The following is a description of a gene set: species: Homo sapiens Gait disturbance The term gait disturbance can refer to any disruption of the ability to walk. Human Gene Set: HP_GAIT_DISTURBANCE, and this is the list of marker genes: PLA2G6, SATB2, MFSD2A, CIITA, NGLY1, SMARCA2, PRPS1, MYF6, GDAP1, FKBP14, SGCD, SPATA7, DNM1, DNM1L, DCC, GARS1, CWF19L1, KARS1, KLHL41, GTF2IRD1, UBE4B, LSM11, PIGW (phosphatidylinositol glycan anchor biosynthesis class W), PRUNE1, FZR1, GRM1, PARK7, NEK1, CPLANE1, IL23R, DAO, RIC1, MT-ND2, CBS, STAC3, EMC1, FKRP, DOCK7, MARS2, CDK19, MTM1, SERAC1, NEXMIF, ACOX1, TBL2, SPRY4, SGCG, PROK2 (NCBI Gene Id 60675), USP9X, COPB2, CHMP2B, SAMD9L, FERRY3, FBXO28, ITPR3, BICD2, AIMP2, MT-TQ, CAPRIN1, EEF2, PTCH1, SET, PACS2, SPTAN1, HACD1, SLC1A2, SORD, CHKB, COL10A1, ATP13A2, SLC25A22, RNU12, NDUFAF6, PDK3, OPHN1 (oligophrenin 1), UCHL1, MT-CO1, MT-TV, MT-CO3, NEFL, SLC25A4, DHH, PNPO, CLIP2, KDM5A, TUBB4A, AP2M1, ORAI1, SPEN, SLC35C1, DHX16, OCA2, LAMB2, REEP2, REPS1 (RALBP1 associated Eps domain containing 1), TGFB1, C4A, CASK, PKP1, EIF2AK3, AARS1, TRAF7, NIPA1, SYT2 (synaptotagmin 2, NCBI Gene Id 6858), FUS (NCBI Gene Id 406232), MCOLN1, ADSS1, KMT2A, C19orf12, PTH1R, CCN6, GRIK2, CRYAB (NCBI Gene Id 1410), NTRK2, NPC1, LETM1, PI4KA, IDH1, POLG, CIZ1, AFG3L2, CHEK2, IL10, ABCB7, PEX2, ABHD16A, IQSEC1, GEMIN5, STIL, DCAF8, UNC80, KCNQ2, CAMK2A, JAG1, KLHL9, RFXANK, ATAD3A, ERCC1, LUZP1, SLC25A46, AP5Z1, TARS1, PPP1R15B, GALT, LARS2, ENSG00000288330, BGN, PHOX2B, GFM2, DHDDS, ATP7B (NCBI Gene Id 540), GYG1, UBQLN2, FDX2, HNRNPA1, ARL6IP1, TUBB2B, CPT1C, MTRFR, PPP2R1A, SCN9A, TARDBP, CTSF, MARS1, HTRA1, IKBKG, TRAPPC10, SLC17A5, ZC4H2, TOR1A, NF2, PLCH1, MMP23B, MUTYH, AHI1, ATAD1, PIGA, SIM1, GLI2, TRIM2, KCNN2, MT-ATP6, GLE1 (NCBI Gene Id 8012), ANO5, COL6A2, STRADA, CHRND, MAST1, SCN1A, LRP12, MT-TF, ESAM, EIF4G1, VPS37A (NCBI Gene Id 23687), DLAT, PRDX3, NT5C2, TREM2, EXTL3, PEX16, BCAS3, GFPT1, PFN1, ERCC4, GJC2, SLC1A4, KBTBD13, PEX11B, IGHMBP2, SNAP25, BAZ1B, TK2, FLNA, JPH3, SNUPN, RFX5, PRRT2 (proline rich transmembrane protein 2), H4C5, SCN8A, UFSP2, CLN5, POC1A, ALK, ERCC2, TCTN1, CSF1R, SNAPC4, VAMP2, CRELD1, EPM2A, ADAT3, CHRNG, SATB1, USP7, SZT2, PIGO, HSD17B10, RPGRIP1L, NKX3-2, ATP10A, LAMA2, HPCA, PRPH, GABRA5, KCND3, CACNA1G, RFC1, EIF2B2, NOP56, COASY, MT-TW, COX6A1, CLN3, FGFR1, INPP5K, SLC35A2, CYFIP2, SCN1B, SPG11, IFRD1, COLQ, AP4E1, ALG2, WARS2, LIMK1, YY1, WDR81, HNRNPH1, IBA57, IQSEC2, KCNQ5, HERC2, DUSP6, PEX1, GNB2, PMP2, NARS1, GRIN2D, MT-TK, PON2, MYO9A, PCDH19, CACNA1E, DARS2, PIGG, ABCA2, NDUFA6, CREBBP, SLITRK2, TRPM3, PACS1, TBP, SLC25A21 (solute carrier family 25 member 21), CAPN3, GIPC1 (NCBI Gene Id 10755), CERS1, VPS37D, PON3, QRICH1, GABRB3, MSH2, COMP, GAA, PREPL, POLE, GJA1, ARCN1, PRKCG, PON1 (NCBI Gene Id 5444), FLVCR1, FIG4, NECAP1, CUX2, SLC2A1, FKTN, FXN, PSEN1, ANXA11, MSH6, MED12, PIBF1, COL2A1, SLC25A1, SCARB2, VPS13C, ANG, TGM6, MAP1B, LARGE1, UBE4A, MEFV (NCBI Gene Id 4210), POLG2, NOTCH3, PNPT1, GGPS1, CCR1, NTNG2, TFG, SLC16A2, CACNA1B, SBF1, LRPPRC, WASHC5, BIN1, CHCHD10, PURA, MLXIPL, DYSF, RPE65, RNASEH2B (ribonuclease H2 subunit B), CHCHD2, PHEX, TMEM237, SLC7A6OS, LMNA, SYNGAP1, GPT2, PTS, ATXN2, TPR, POLR3A, GAS1, DNA2, TKFC, DUX4, PDGFRB, PRKCZ, DYNC1I2, HYLS1, POGLUT1, CDK10, SLC13A5, FOXH1, TNNT1, PPP1R21, NTNG1, ST3GAL3, ADSL, SCO2 (NCBI Gene Id 9997), MTFMT, ELOVL5, PMPCB, DHX30, ERCC3, COQ4, ATP7A, GNB4, KMT2B, NACC1 (nucleus accumbens associated 1), GNPNAT1, MICOS13, TTN, CHST3, ADCY5, FKBP6, EIF2B5, HYCC1, MAN2B1, DPYD, CHD2, EBF3, KCNC2, TPI1, PRKN, GNAO1, KAT6A, IRF2BPL, PIGS, SIX3, COPB1, PRX, ERCC6, SLC18A2, KCNA1, TPK1, MT-ND1, TAFAZZIN, CHKA, RNASEH2A, NAA80, MAFB, ATM, ATP5MC3, PROKR2, KIF1A, CLDN11, KY, LRP5, HLA-B, LMO1, TMEM106B, SIGMAR1, SH3TC2, NAA20, PHKA1, RHOBTB2, TPM2, SQSTM1, TTPA, DOHH, SPTSSA, ARX, CA8, GABRA2, KCNAB2, CHD4, MYH2, PNPLA8, ITPR1, SPTLC1, TBC1D23, CTNNA2, GRIA4, PPARGC1A, AIFM1, BCL11A, PODXL, CHAMP1, TACO1, CTBP1, OGDH, ZBTB20, CLCN2, AQP4, GABRA1, CDK8, NDUFAF2, GJB1, PDPN (podoplanin), EIF2B4, TBC1D2B, GPRC5B, GRIA2, DYNC1H1, GAN, UBA5, NDNF, HEXB, RAI1, MAPK10, PSAP, MYH7, UNC13A, DYRK1A, ZFTA, LYST, TSPOAP1, RFXAP, PSMC1, CCNF, SNORD118 (small nucleolar RNA, C/D box 118), TMCO1, AP4B1, PIK3CA, MLH1, MFF, CC2D2A, SHH, HS6ST1, SGCA (NCBI Gene Id 6442), GTF2I, WNT1, DDX6, OPTN, GRIN1, FBXO7, SMS, XYLT2, SUCLG1, FAT2, MTR, ZMPSTE24, DDHD1, CLCN4, MTOR, PHIP, YWHAG, CYP2R1, TECPR2, TNR, SLC34A3, NKX2-1, CARS1, ARL13B, NEUROD2, DMD, LONP1, FAM149B1, TRMT10A, ATXN3, COL9A2, CAPN1, UBAC2, TERT, VPS13A, HMBS, ERLIN2, ATL3, ARG1 (NCBI Gene Id 383), SNCA, NAA10, SLC2A3, SYNE1, THOC2, HACE1, DHPS (NCBI Gene Id 1725), SCN3A, PTRHD1, DES, KCNB1, ERMARD, PNPLA6, SMARCB1, MT-TL1, MED25, TGFBR2, PEX6, HPDL, PIK3R5, CCDC28B, MTRR, IMPDH2, TMEM43, ELN, YARS1, EIF2S3, HSD17B4, ATP5F1D, RFC2, TMEM107, PRKAR1B, DDHD2, RPS6KA3, STXBP1, MAG, POGZ, GBE1, FDXR, PIGL, COL13A1, POU4F1, POLR1A, FARS2, GLRA1, DLL1, DNAJC13, MAB21L1, SCYL1, SLC30A9, SLC6A8, BAP1, DNAJB2, POLR3B, TCTN3, ACBD5, CYP27B1, SDHB, SLC9A7, DSTYK, PDE2A, VWA3B, MSTO1, COQ7, NAXD, PDHA1, SLC34A1, SPTBN2 (spectrin beta, non-erythrocytic 2), AASS, SPAST (NCBI Gene Id 6683), PIGV, AOPEP, SCN2A, ARL6, DUX4L1, ALAD, HSPB3, FLNC, MT-ND3, MYPN, FHL1 (NCBI Gene Id 2273), FMR1, SLC39A14, MT-TT, SRCAP, ERAP1, NBEA, INF2, SLC39A13 (NCBI Gene Id 91252), PMS1, CFAP43, ATXN1, PPM1D, DDX3X, ISCU, SLC26A2, GLB1, SDHAF1, VARS1, NOG, RFX7, ANO10, RERE, MT-TH, LIN28B, PUS3, TTI1, WWOX, SMARCAL1, TSEN15, MPZ, KIDINS220 (kinase D interacting substrate 220), TCTN2, TMEM216, ZIC2, XRCC1, MT-TE, BVES, PLCB1, NUBPL, LMX1B, PRDM5, MAN1B1, RRM2B, SLC30A10, RRM1, NDUFS8, ENTPD1, PLEC (NCBI Gene Id 5339), AGTPBP1, KRAS, CACNA1A, ARSI, ERBB4, INPP5E, NDRG1, MMADHC, PITRM1, GOSR2 (golgi SNAP receptor complex member 2), MTTP, GCH1, BRAT1, KPNA3, ACTN2, FLII, NUP54, SAMHD1, CCDC88C, RNF113A, ASXL1, FRG1, REEP1, DCPS, SBF2, FA2H, TRPC3, KIF1C, CTCF, DNAJC12, PIGY, LRAT, RNU4-2 (NCBI Gene Id 26836), GNPTAB, GABRB2, ATXN10, PDGFB, MAPK8IP3, MORC2, RYR1, APP (NCBI Gene Id 351), STX1A, ALDH4A1, PDP1, RAB39B, SLC6A5, MAP3K20, GPHN, DNM2, SGCB, STAG2, ATP2B3, CEP120, ABCD1, SMN2, USP8, APOE, EPRS1, HADHB, SLC38A3, INTS1, DOK7, WDR48, KDM5B, DNAJC3, KIF5A, PPIB, LAMP2, CSPP1, WDR45B, CRAT, HTRA2, VPS33A, SNRPN, DYM, UROC1, POT1, TIMM8A, TBC1D24, WDR26, TAF1, APC, ARL3, LYRM7, MTPAP, BSCL2, ERCC8, THG1L, ASAH1, CAD, IL12A, EGR2, SOX10, FGF8, WASF1, FKBP10, TOP3A (DNA topoisomerase III alpha), IL17RD, TRIM32, APTX, VDR, LMNB1, CHAT, PLEKHG4, SHQ1, VPS41, KLC2, BRCA2, GTF2E2, TCEAL1, LYSET, COL12A1, SLC12A6, POMT1, DKK1, B3GALNT2, BUD23, MECP2, BCL11B, GBA2, FGF12, TRIO, NR4A2, MATN3, SMPD1, TMEM163, RAPSN, MYO1H, PMP22, DHTKD1, UBTF, DNAJB6, SMO, CNPY3, TMEM67, B9D2, PI4K2A, NEFH, ATN1, B4GALNT1, PIGP, SLC9A6, AFG2A (NCBI Gene Id 170576), PDE8B, MT-ND5, MME, SPG7, VPS35, CYP27A1, HNRNPK, DEAF1, B9D1, ATXN8OS, COA7, L1CAM, KIF7, INTS8, TMEM270 (NCBI Gene Id 135886), ASXL3, TREX1, CACNA2D2, DCTN1, LPIN1, MECR, GDAP2, TMEM63C, PSMB1, POU3F4, TPM3, TAF4, DNAJC6, THRA, NDUFA1, EP300, CDON, GMPPB, PLEKHG5, RUSC2, HNRNPH2, MBOAT7, TCAP, CACNA1I, CRPPA, RNASEH2C, HLA-DQB1, PDYN, LRP4, GOT2, TBK1, SELENOI, KCNA2, JAG2, RNU7-1, POMGNT1, SURF1, SPG21, SLC6A1, TUBB3, PPP3CA, GIGYF2, TRAPPC6B, PIEZO2, OTUD7A, CNKSR2, RAB7A, CCT5, MFN2, SLC20A2, NCF1, AR, TMEM240, MYCN, TTC19, MRE11, GNE, CANT1, MGAT2, KCNJ10, TANGO2, FTL, CRIPTO, EXT2, SNCAIP, AP1S2, TMEM231, WNT3A, SDHD, PCNA, AGRN, SMN1, FGD4, CEP104, SEC31A, GRID2, TOPORS, MAPT, SLC19A3, SLC12A5, SEMA3A, TYROBP, PEX10, NRXN1, KLRC4, PRNP, MKS1, XRCC4, SIL1, FAR1, AP3B2 (adaptor related protein complex 3 subunit beta 2), TPP1, DISP1, COL9A3, PLOD1, IFNGR1, SACS, CERT1, PGAP1, TNPO2, COL6A3, SPEG, LDB3, IFT74, IFIH1, HTT, ATCAY, MIEF2 (NCBI Gene Id 140774), MT-ND4, MMP13, SMARCE1, ACAN, TNNC2, SPART, MPV17 (mitochondrial inner membrane protein MPV17), MRPS34, SMC1A, POMT2, PRDM13, OBSCN, TEFM (NCBI Gene Id 79736), FN1, RARS1, GBA1, PANK2, DALRD3 (DALR anticodon binding domain containing 3), TCF4, CYP7B1, UQCRQ, ZSWIM6, CLTC, ALS2, PHKG1 (phosphorylase kinase catalytic subunit gamma 1), CCDC141, RLIM, PTEN (phosphatase and tensin homolog), EIF2B3, ALPL, STUB1, ALDH18A1, DOCK3, PDHX, ARMC9, MEGF10, HCN1, NUP62, IL12A-AS1, NEU1, CACNA2D1, OTUD6B, FLRT3, SDHA, RETREG1, ZFYVE26, P4HTM, COQ2, PDE10A (NCBI Gene Id 90632), LNPK, FBXO38, VPS13D, RBM10, CFL2, RUBCN, SETX, TINF2, FAS, ZEB2, HSPD1, ATP1A2, SLC18A3, DNAJC30, CP, PGAP3, PAX7, ADAM22, SNX14, GPAA1, AMPD2, CBY1, ZNF469, SOD1, MEF2C, SMCHD1, FGF17, MYOT, TH, COQ5, ZFR, TOGARAM1, GABBR2, TBCK, MYH3, GSX2, TRAPPC11, RTN2, ATL1, RNF170, TRIP4, FBN1, RILPL1, TACR3, SLC39A8, VAC14, RPL10, EXOSC5 (exosome component 5), FRRS1L (NCBI Gene Id 23732), CUL4B, SYNJ1, ACTB, DPAGT1, TIA1, CYP2U1, FOXG1, SYT1, LMNB2, MPLKIP, SKI, ERBB3, RSPRY1 (ring finger and SPRY domain containing 1), NKX6-2, SCN4A, SYNE2, SYT14, WDR11, SUFU, UBAP1, NODAL, DNMT3B, ATP6AP2, CDKL5, RAB18, PLAAT3, VLDLR, CLN8, CLIC2 (NCBI Gene Id 1193), FNIP1, FGF14, BBS1, SLC25A15, HINT1, KCNT1, MARCHF6, SMG8, FOXRED1, MTHFR, FEZF1, EIF2AK2, KIAA0753, FCSK, LMOD3, PEX5, UBE3A, VCP (NCBI Gene Id 94731), PRKRA, HSPB1, GTPBP2, BCORL1, CHD3, GBF1, TMEM222, MAGEL2, GCDH, ACOX2, COL9A1, PDE6D, VPS16, GNS, HESX1, NAT8L, PPP2R5D, ZNF526, DAG1, OPA1, HMGCR (NCBI Gene Id 3156), NEB, SLC9A1, MMP2 (NCBI Gene Id 4313), MBTPS1, TBR1, VAPB, TAF15, HARS1 (histidyl-tRNA synthetase 1), ABHD5, AP4M1, NUS1, CAMTA1 (NCBI Gene Id 23261), ATP6V1A, NEUROG1, ASPA, KIAA0586, NUDT2, SLC33A1, LRRK2, CAMK2B, CHD7, RNASEH1, LTBP4, COA8, OFD1, KIF1B, LITAF, KATNIP, MICU1, TBC1D20, GABRG2, MATR3 (matrin 3), TELO2, TLK2, GRN, PPP2R2B, AHDC1, GLRB, ALG14, NTRK1, ARID1B, RNF168, TTBK2 (NCBI Gene Id 26044), SPTBN1, EIF4H, YME1L1, METTL27, ERLIN1, CELF2, GEMIN4, TGIF1, POLD1, STAT4, HK1, ACTA1, TRPV4, GRIN2A, NFU1, DPM3, MTMR14, PCDH15, TRAK1, TBCD (tubulin folding cofactor D), NPHP1, SUCLA2, HADHA, TRAPPC2L, PLD3, CASZ1, POPDC3, FUCA1, GNB1, EIF2B1, TDP1, OPA3 (NCBI Gene Id 8186), NHLRC1, SLC5A7, COL6A1, NPR3 (NCBI Gene Id 79614), ACTL6B, MT-TS2, MT-CO2, JARID2, VAMP1, MED23, BMPR1A, SHANK3, MUSK, PRDM16, RAB11B, MCM3AP, HNRNPA2B1, ATP8A2, RANBP2, CPLX1, ATP1A3, TLR4, NSUN2, GTF2IRD2 (NCBI Gene Id 84163), ADAR, GLRX5, ADH1C, GALNS, PNPLA2, HSPG2, PARS2, PINK1, WARS1, ELP1, PAK1 (p21 (RAC1) activated kinase 1), EPCAM, KCNA4, FLRT1, SLC25A19, CHMP1A, KDM5C, RPS20, SHMT2, EEF1A2, LCA5, SLC6A17, RNF125, FBP2, SPTLC2, AKT1, PYCR2, PMPCA, EED, WLS, BEAN1, NOTCH2NLC, PABPN1, EMD, AP4S1, GALC (galactosylceramidase), ELOVL4, HERC1, CEP41, ATP1A1, GABRD, CAV1 (NCBI Gene Id 857), SEMA4A, SLC52A3, TWNK, ADGRG1, BAG3, PMS2, DAB1, LRSAM1, GTF2H5, SELENON, ANOS1, ARSA, PLP1, KCNC3, PGAP2, MDH2, MT-ND6, CFAP410, VPS51, TMEM218, GLT8D1 (NCBI Gene Id 91870)